The following is a description of a gene set: from publication Turjanski AG, Vaqué JP, Gutkind JS (PMID 17496919) species: Homo sapiens Examples of transcription factors whose activities are regulated by MAPK1 and MAPK3 phosphorylation. Human Gene Set: TURJANSKI_MAPK1_AND_MAPK2_TARGETS The mitogen-activated protein kinases (MAPKs) are a family of serine/threonine kinases that play an essential role in signal transduction by modulating gene transcription in the nucleus in response to changes in the cellular environment. They include the extracellular signal-regulated protein kinases (ERK1 and ERK2); c-Jun N-terminal kinases (JNK1, JNK2, JNK3); p38s (p38alpha, p38beta, p38gamma, p38delta) and ERK5. The molecular events in which MAPKs function can be separated in discrete and yet interrelated steps: activation of the MAPK by their upstream kinases, changes in the subcellular localization of MAPKs, and recognition, binding and phosphorylation of MAPK downstream targets. The resulting pattern of gene expression will ultimately depend on the integration of the combinatorial signals provided by the temporal activation of each group of MAPKs. This review will focus on how the specificity of signal transmission by MAPKs is achieved by scaffolding molecules and by the presence of structural motifs in MAPKs that are dynamically regulated by phosphorylation and protein-protein interactions. We discuss also how MAPKs recognize and phosphorylate their target nuclear proteins, including transcription factors, co-activators and repressors and chromatin-remodeling molecules, thereby affecting an intricate balance of nuclear regulatory molecules that ultimately control gene expression in response to environmental cues., and this is the list of marker genes: SP1, SMAD4, SMAD1, TP53, ELK4, MYB, SMAD3, MAFA, SMAD2, ELK1, FOS, MYC (MYC proto-oncogene, bHLH transcription factor)